Given this list of marker genes Guca2a, Amy2a3, Amy2a2, Lipf, Pnliprp1, Alpi, Lct, Sis, Pnlip, Chia1, Amy2a4, Chit1, Pir, Pnliprp2, here is a description of the gene set: This event has been computationally inferred from an event that has been demonstrated in another species.<p>The inference is based on the homology mapping from PANTHER. Briefly, reactions for which all involved PhysicalEntities (in input, output and catalyst) have a mapped orthologue/paralogue (for complexes at least 75% of components must have a mapping) are inferred to the other species. Reactome Pathway: Digestion part of: Digestion and absorption electronically inferred by orthology from the curated human pathway species: Mus musculus